The following is a description of a gene set: studied in species Mus musculus from publication Chen Y, Wang X (PMID 31504780) Genes predicted to be targets of miRBase v22 microRNA mmu_miR_412_5p in miRDB v6.0 with MirTarget v4 prediction scores > 80 (high confidence targets). Mouse Gene Set: MIR_412_5P, and this is the list of marker genes: Xpo1 (exportin 1), Fat2, Pcdh10, 2300002M23Rik, Dennd3